Given this list of marker genes Ezh2, Cpt1a, Ezh1, Nqo1, Igf2r, here is a description of the gene set: Mouse Gene Set: GOBP_RESPONSE_TO_TETRACHLOROMETHANE studied in species Mus musculus Any process that results in a change in state or activity of a cell or an organism (in terms of movement, secretion, enzyme production, gene expression, etc.) as a result of a tetrachloromethane stimulus.